Given this list of marker genes Rab1a, Gorasp1, Gorasp2, Mapk3, Plk1, Golga2, Rab2a, Mapk1, Rab1b, Blzf1 (NCBI Gene Id 66352), here is a description of the gene set: Golgi Cisternae Pericentriolar Stack Reorganization Mouse Gene Set: REACTOME_GOLGI_CISTERNAE_PERICENTRIOLAR_STACK_REORGANIZATION studied in species Mus musculus